Given this list of marker genes SNTA1, KCNJ5, SCN5A, CALM1, KCNE1, ANK2, CAV3, CALM3 (calmodulin 3), AKAP9 (A-kinase anchoring protein 9), SCN4B, TBX5, SCN10A, TRDN, CACNA1C, KCNE2, KCNQ1, KCNH2, NOS1AP, CALM2 (NCBI Gene Id 805), here is a description of the gene set: species: Homo sapiens Human Gene Set: HP_ABNORMAL_CARDIAC_EXERCISE_STRESS_TEST Abnormal cardiac exercise stress test Abnormal results of exercise on heart function.